Given this list of marker genes Mgst2, Gstm4 (NCBI Gene Id 68555), Glo1, Alox5ap, Cenpv, Ltc4s, Mgst3, Cth, Hccs, Scly, Kyat1, Kyat3, here is a description of the gene set: Catalysis of the elimination of hydrogen sulfide or substituted H2S. studied in species Mus musculus Mouse Gene Set: GOMF_CARBON_SULFUR_LYASE_ACTIVITY